Given this list of marker genes NOTCH2NLC, GIPC1, PLCB4, EDN1, TUBB4A, RILPL1, FRAS1, GNAI3, MTPAP, LRP12, GAA, ALS2, POLG, ATP13A2, SH3TC2, SBF2, here is a description of the gene set: Movement abnormality of the tongue studied in species Homo sapiens Human Gene Set: HP_MOVEMENT_ABNORMALITY_OF_THE_TONGUE